The following is a description of a gene set: species: Homo sapiens The migrating motile tip of a growing nerve cell dendrite. Human Gene Set: GOCC_DENDRITIC_GROWTH_CONE, and this is the list of marker genes: HSP90AB1, MAP2, COBL, CDKL5, HSP90AA1, PTCH1, TAOK2, MAPK8IP1